The following is a description of a gene set: studied in species Homo sapiens The cellular metabolic process in which a cell duplicates one or more molecules of DNA. DNA replication begins when specific sequences, known as origins of replication, are recognized and bound by the origin recognition complex, and ends when the original DNA molecule has been completely duplicated and the copies topologically separated. The unit of replication usually corresponds to the genome of the cell, an organelle, or a virus. The template for replication can either be an existing DNA molecule or RNA. Human Gene Set: GOBP_DNA_REPLICATION, and this is the list of marker genes: STN1, FAF1, RECQL5, ETAA1 (ETAA1 activator of ATR kinase), RFWD3, CDC34, RBMS1, JADE1, GLI2, ORC5, CACYBP, AGER, TIPIN, MCM8, JADE2, MEAF6, POLB, BLM, FBXO5, SSRP1, TREX1, EREG, MCM5, CHEK1, NUGGC (nuclear GTPase, germinal center associated), NT5M, DYNLL1, POLH, NASP, TSPYL2, ATF1, EHMT2, RBBP7, UPF1, KIN, PCLAF, TK1, FEN1, SDE2, CHTF8, MCIDAS, WEE1, RFC4, SMARCAL1, MCM10, POLE2, TIMELESS, EME1, TERF1, ORC3, RAD50, S100A11, TWNK, UCHL5, MCMBP, CDT1, CDC7, GMNN, MCM7, SUPT16H, GRWD1, CHTF18, POLE4, GMNC, JADE3, WIZ, POLD3, RFC5, RAD17 (NCBI Gene Id 5884), CINP, GEN1, DTD1, CDC25A, ADRA2A, FBH1, MCM4, WDHD1, METTL4, ACVRL1, CDK1, POLA1, FAM111A, USP37, POLI, LIG3, TEFM, NUCKS1, CAMSAP3, PRIM2, GINS3, NFIX, DSCC1, CDKN1B, GINS2, NFRKB, YY1 (NCBI Gene Id 7528), ZPR1, CDK9, SLX4 (NCBI Gene Id 84464), ORC1, ZBTB38, ID3, DACH1, ACTL6A, CDC45 (NCBI Gene Id 8319), RBBP8, EGFR, LIG1, OBI1 (ORC ubiquitin ligase 1), INO80D, PRIMPOL, RMI2, TFPT (NCBI Gene Id 29844), WAPL, MCM3, POLK, RFC2, OOEP, CDKN1A, WDR18, EXO1, POLD2, GTPBP4, CCNE1, TICRR, POLG2, CCNE2, ACTR8, MCRS1, MUS81, PTK6, CENPX, RBBP4 (RB binding protein 4, chromatin remodeling factor), CCNA2, FAM111B, GLI1, INO80E, GDF2, FGFR1, KAT7 (NCBI Gene Id 63437), DONSON, BOD1L1, DUT, PCNA, BCL6, CIZ1, POLD1, INO80B, ESCO1, RNASEH1, PTMS, ANKRD17, ENPP7, POLA2, ORC2, GINS4, TOP1MT, DDX11, HELB, KCTD13, TRAIP, ASF1A, FANCM, SMC3, PDS5A, RTEL1, INO80, NOC3L, RPA4, ZNF830, ZRANB3, CARM1, CTC1, BARD1, RPA2, DTL, ENDOG, POLD4 (DNA polymerase delta 4, accessory subunit), RECQL, GINS1, AICDA, WRN, DHX9, E4F1, POLE, RRM2B, POLE3, REV1, POLQ, CDC6, BRCA2, TBRG1, DNA2, ATRX, NFIA, SSBP1, MRE11, ACTR5, ZMPSTE24, TERF2, TP53, RPA3, HCRT, DNAJA3, NBN, RUVBL1, SMARCA5, TONSL, TOP1, MGME1, POLL, SENP2, RTF2, CHAF1B, ZNF365, WRNIP1, NFIC, STRA8, RNASEH2A, E2F7, MCM9, EME2, PURA, BAZ1A, CDK2AP1, MCM6, DBF4, PNKP, MMS22L, SLFN11, RPA1, CHAF1A, KHDC3L, RBBP6, CENPS, NAP1L1, TOPBP1, ATR, BRPF3, SAMHD1 (SAM and HD domain containing deoxynucleoside triphosphate triphosphohydrolase 1), POLN, ING5, E2F8, UCN, PRIM1, NPM2 (NCBI Gene Id 286056), RMI1 (RecQ mediated genome instability 1), TNFAIP1, DBF4B, SIN3A, PARP1, ORC6, RFC1, TTF1, MCM2 (minichromosome maintenance complex component 2), ATAD5, RUVBL2, SET, DNAJC2, REV3L, POLG, RRM1, ORC4, RECQL4, POLRMT, RAD51, LRWD1, INO80C, NFIB, BRCA1, ESCO2, SETMAR, CHRAC1, NYNRIN, EXD2, CDK2, RFC3